The following is a description of a gene set: Genes containing one or more binding sites for (Mau2) in their promoter regions (TSS -1000,+100 bp) as identified by GTRD version 20.06 ChIP-seq harmonization. Mouse Gene Set: MAU2_TARGET_GENES species: Mus musculus from publication Yevshin I, Sharipov R, Kolmykov S, Kondrakhin Y, Kolpakov F (PMID 30445619), and this is the list of marker genes: Asf1b, Vipas39, Duxf1, Ift20, mt-Nd4l, Cramp1, Tnfaip1, Syngr4, Rfwd3, mt-Nd4, Gm10644, Hmgcr, Hsd17b12, Slc25a19, Nkapl, Emsy, Dnajc30, Epg5, Celf6 (CUGBP, Elav-like family member 6), Scamp3, Map2k1, Lims1, Cables2, Kat6a, Clk1, Tubb4b (tubulin, beta 4B class IVB), Eif2s1, Ccdc117, Zbtb5 (zinc finger and BTB domain containing 5), Dleu2, Chst15, Ahsa1, mt-Nd3, Spata19, Mrpl34, Sh3gl1, Bud23, mt-Tv, Cebpz, Speer4e2, Drc3, Triobp, Tom1l2, Taf6l, Inpp4b, mt-Tg, mt-Tr, Ift140, Ndufaf7, Gm8357, Gm15564, Lix1l, Cdc20, Uba6, Dguok, Nectin1, G6pc2, Bmal1, Lin52, Ice1, Ddt, Hmgcs1, Pnn, Pcx, mt-Rnr2, mt-Nd1, 1700055D18Rik, Adgrv1, Fam43a, Aldh6a1, mt-Tl1, Kxd1, Rpl30, Vars1, Atp6v1d, mt-Cytb, Tmem143, Ube2f, Lrrc59, Thumpd3, Ak2, Gm27017